Given this list of marker genes SMARCC2, ARID1B, ACTB, SMARCD3, SS18L1, DPF2, SMARCD1, SMARCE1, ACTL6B, SMARCA2, SMARCA4, DPF1, DPF3, SMARCC1, ARID1A, SMARCB1, here is a description of the gene set: A SWI/SNF-type complex that is found in post-mitotic neurons, and in human contains actin and proteins encoded by the ARID1A/BAF250A or ARID1B/BAF250B, SMARCD1/BAF60A, SMARCD3/BAF60C, SMARCA2/BRM/BAF190B, SMARCA4/BRG1/BAF190A, SMARCB1/BAF47, SMARCC1/BAF155, SMARCE1/BAF57, SMARCC2/BAF170, DPF1/BAF45B, DPF3/BAF45C, ACTL6B/BAF53B genes. The nBAF complex along with CREST plays a role regulating the activity of genes essential for dendrite growth. studied in species Homo sapiens Human Gene Set: GOCC_NBAF_COMPLEX